Given this list of marker genes KIF13A, FBXW5, GNG11, TUBA3E, GNAQ, HDAC3, CCT8, PFDN4, GNG4, CCT3, ARFGEF2, TUBB2A, CSNK2A1, KIFC3, FBXL5, GNB1, CCT5, CCNE2, GNB3, DCAF7, LONP2, FBXO4 (NCBI Gene Id 55087), GNB5, FBXW4, PFDN1, SPHK1, TCP1, RGS7, CCT7, FBXW2 (F-box and WD repeat domain containing 2), TUBA1A, GNB4, TUBB4B (tubulin beta 4B class IVb), STAT3, TUBB3, GNB2, FBXO6, TBCB, ARL2, GNGT2, TUBA1C, TUBA1B, TP53 (NCBI Gene Id 7157), TBCA, VBP1, GNG12, SKIC2, TBCD, TUBAL3, FBXW7, GNG8, GNG10, GNA11, PFDN2, CSNK2B, GNG2 (G protein subunit gamma 2), TUBB4A, XRN2, GNG3, FBXL3, FBXW10, FBXW9, USP11, GNG7, TUBB2B, TUBA3D, TUBB6, TBCE, GNGT1, CCT4, GAPDHS, CSNK2A2, PFDN5, CCT6A (chaperonin containing TCP1 subunit 6A), RGS11, TUBB1, CCT2, RGS9, ACTB, PFDN6, GNA15, TUBA4A, WRAP53, CCT6B, AP3M1, FKBP9, GNG13, TUBA3C, RGS6, GNA14, GNG5, TUBA8, CCNE1, NOP56, TBCC, PDCL, GBA1, TUBA4B, here is a description of the gene set: studied in species Homo sapiens Protein folding Human Gene Set: REACTOME_PROTEIN_FOLDING